The following is a description of a gene set: Mouse Gene Set: GOBP_POSITIVE_REGULATION_OF_PLASMINOGEN_ACTIVATION studied in species Mus musculus Any process that increases the rate, frequency or extent of plasminogen activation. Plasminogen activation is the process in which plasminogen is processed to plasmin., and this is the list of marker genes: Clec3b, Anxa2, Meltf, F12, Eno1b, Plgrkt, S100a10, Hpn, Eno1